Given this list of marker genes RB1, E2F3, CCNE1, E2F2, E2F1 (E2F transcription factor 1), CDK2, here is a description of the gene set: Pathway Definition from KEGG: (CCNE*+CDK2) -> RB1 // E2F studied in species Homo sapiens Human Gene Set: KEGG_MEDICUS_VARIANT_AMPLIFIED_CCNE_TO_CELL_CYCLE_G1_S Amplified CCNE to cell cycle G1/S. Pathway ID: N00255. Pathway type: Variant. Pathway class: nt06261 Gastric cancer.